Given this list of marker genes GYS1, RPS27A, EPM2A, UBB, PPP1R3C, NHLRC1, UBA52, GYG1, UBC, here is a description of the gene set: Reactome Pathway: Myoclonic epilepsy of Lafora part of: Glycogen storage diseases studied in species Homo sapiens Lafora disease is a progressive neurodegenerative disorder with onset typically late in childhood, characterized by seizures and progressive neurological deterioration and death within ten years of onset. Recessive mutations in EPM2A (laforin) and NHLRC1 (malin) have been identified as causes of the disease. The disease is classified here as one of glycogen storage as EPM2A (laforin) and NHLRC1 (malin) regulate normal glycogen turnover and defects in either protein are associated with the formation of Lafora bodies, accumulations of abnormal, insoluble glycogen molecules in tissues including brain, muscle, liver, and heart. Consistent with a central role for glycogen accumulation in the disease, reduced or absent glycogen synthase activity prevents Lafora Disease in mouse models.<p>Type 2A disease. EPM2A (laforin) associated with cytosolic glycogen granules, normally catalyzes the removal of the phosphate groups added rarely but consistently to growing glycogen molecules. Defects in this catalytic activity lead to the formation of phosphorylated glycogen molecules that are insoluble and that show abnormal branching patterns.<p>Type 2B disease. NHLRC1 (malin) normally mediates polyubiquitination of EPM2A (laforin) and PPP1R3C (PTG). The two polyubiquitinated proteins are targeted for proteasome-mediated degradation, leaving a glycogen-glycogenin particle associated with glycogen synthase. In the absence of NHLRC1 activity, EPM2A and PPP1R3C proteins appear to persist, associated with the formation of abnormal, stable glycogen granules (Lafora bodies). In NHLRC1 knockout mice PPP1R3C levels are unchanged rather than increased, suggesting that NHLRC1 does not target PPP1R3C for degradation. However, EPM2A protein levels are increased in this knockout consistent with NHLRC1's proposed role.